Given this list of marker genes RET, NKX2-3, ID2, FOXL1, RORC, CACNB4, STAT5A, ADA, STAT5B, TOX, ARTN, here is a description of the gene set: Human Gene Set: GOBP_MUCOSA_ASSOCIATED_LYMPHOID_TISSUE_DEVELOPMENT studied in species Homo sapiens The process whose specific outcome is the progression of mucosal-associated lymphoid tissue over time, from its formation to the mature structure. Mucosal-associated lymphoid tissue is typically found as nodules associated with mucosal epithelia with distinct internal structures including B- and T-zones for the activation of lymphocytes.